The following is a description of a gene set: Human Gene Set: HP_DISTAL_LOWER_LIMB_AMYOTROPHY studied in species Homo sapiens Muscular atrophy of distal leg muscles. Distal lower limb amyotrophy, and this is the list of marker genes: PTRHD1, FLRT1, FBLN5, KLC2, DNAJB2, TFG, PDK3 (pyruvate dehydrogenase kinase 3), MTRFR, NEFL, DYSF, ADSS1 (adenylosuccinate synthase 1), RILPL1, SPG11, FLNC, ALS2, B4GALNT1, COL6A1, MPV17, PMP22, RTN2, GJB1, BICD2, GIPC1, AARS1, HSPB1, NOTCH2NLC, TRPV4, ATL1, KIF5A (kinesin family member 5A), KRT14, CUL4B, RAB7A, TTN, YY1, MORC2, SLC12A6, TCAP, LRP12, MUSK, BSCL2, GNB4, WARS1, RYR1, HINT1, ATXN3, KDM5C, MYH7, KRT5, MFN2, TPM3, SPTAN1, MME, FGD4, MT-TE, MAG, SCO2, CADM3, INF2, AIFM1, LMNA, CPT1C, HSPB3, HK1